The following is a description of a gene set: Human Gene Set: GSE17721_CPG_VS_GARDIQUIMOD_0.5H_BMDC_UP mouse primary BMDCs were stimulated with tlr ligands and gene expression changes were profiled on Affymetrix arrays from publication Amit I, Garber M, Chevrier N, Leite AP, Donner Y, Eisenhaure T, Guttman M, Grenier JK, Li W, Zuk O, Schubert LA, Birditt B, Shay T, Goren A, Zhang X, Smith Z, Deering R, McDonald RC, Cabili M, Bernstein BE, Rinn JL, Meissner A, Root DE, Hacohen N, Regev A (PMID 19729616) studied in species Homo sapiens Genes up-regulated in comparison of dendritic cells (DC) stimulated with CpG DNA (TLR9 agonist) at 0.5 h versus DC cells stimulated with Gardiquimod (TLR7 agonist) at 0.5 h., and this is the list of marker genes: SS18L2, BMPR2, GLRA3, MAF, HMGCL, GPRC5B, ATP1B2, FAM120A, CPB1, PFDN5, SOX5, GTSF1L, RAB3B, RHBG, MAP1LC3B, ATP6V1E2, SYTL1, TYR, IRF2, IQCC, CPA5, ACOT1, CDC25C, HCRT, FGFR1, GDF11, CACNB4, GSX1, H6PD, SYT12, MTURN, LIPT1, PON3, UQCR10, SUCO, BTG1, ERG28, WDR75, ALKBH3, GFRA3, ALDOB, BICD2, SPAG4, P2RX7, NAA15, SLC48A1, THSD1, SRPX2, THBS3, PDE10A, DOLPP1, GLIS1 (NCBI Gene Id 148979), INVS, RABEP1, TRAF4, ANGPTL1, CLDN3, MT1E, CASP1, HOXD9, INTS8, ANKRD46, FTSJ3, GLRX3, RPP21, USP17L2, NT5E, CSDE1, KRT1, DRAM2, LAMTOR4, MTFR1L, NOS2, ATP5F1D, ZNF227, CCR2, LEPROT, RNF144B, GADD45B, CCNG1, ITPK1, NCAN, FOXA2, ROPN1, C6orf120, SYNPR, SLC38A2, HOMER1 (homer scaffold protein 1), PIGC, DNAJC17, CALHM5, CHCHD5, SUGT1, RXFP2, IDO1, DIPK2A, IFI27L2, TAF7, ATP5MC1, BCAP29, ZNF207, HEMGN, ARHGAP5, SLC15A3, CHRD, PRRT1, CHRND, CHRNB4, PRMT7, MYCT1, MYCBP, PLG, AIF1, RGS1, CLN5, GDI1, TMEM186, ACKR2, PTRH2, CDH13, MPC1, YTHDF2, ALS2CL, PITPNB, NOLC1, PNO1, UBE2B, RPS25, NDUFS8, ACTL7A (actin like 7A), KLHDC3, EPB41L5, NDUFA6, KREMEN1, LAMA4, RXRG, HMCES, PSENEN, ABCB7, LCOR (NCBI Gene Id 93376), SERINC1, KERA, PRSS16 (serine protease 16), RPS14, OSCAR, CCL17, GPR88, RNF183, RPL26, C16orf89, STAP1, TTC27, BCAR1, LEFTY1, RPL41, WDFY3, PLCB2 (phospholipase C beta 2), COX6B1, TFIP11, RPS5, TRAF3IP2, EPHA6, CIB1, UQCR11, NCBP2, MTHFS, GRK5, DBI, AURKB, B3GALNT2, COPB2, SNX29, SNRPB2, SP1, DMXL1, GBP6, SACM1L, FASTKD2, RPL23A, SUOX, MTFP1, RPL37A, PRSS22, GPR65, NRIP3, NDUFB4, FGF5, C1GALT1C1, NABP1, SMU1, TPR, CNOT2, RPE, GLA, UQCRQ, PLGRKT, NDUFC1 (NCBI Gene Id 4717), RPL22L1, CABP5